The following is a description of a gene set: species: Mus musculus The chemical reactions and pathways involving lipoxin A4. Lipoxin A4 is a C20 hydroxy fatty acid having (5S)-, (6R)- and (15S)-hydroxy groups as well as (7E)- (9E)-, (11Z)- and (13E)-double bonds. Mouse Gene Set: GOBP_LIPOXIN_A4_METABOLIC_PROCESS, and this is the list of marker genes: Cyp4f13, Ptgr1, Alox8, Alox12, Alox15